The following is a description of a gene set: species: Mus musculus Mouse Gene Set: chr14D2, and this is the list of marker genes: Mlnr-ps, Chmp7, Gm23735, Tnfrsf10b, Nudt18, Gm4251, Gm22725, R3hcc1, 4930434J06Rik, Gm4240, Ccar2, Egr3, Npm2, Xpo7, Nkx2-6, 4930429C20Rik, Dmtn (NCBI Gene Id 13829), 2410012E07Rik, Gm16867, 1700092C10Rik, Gm27179, Bmp1 (bone morphogenetic protein 1), Rps2-ps5, Pdlim2, Phyhip, Loxl2, Entpd4 (ectonucleoside triphosphate diphosphohydrolase 4), Polr3d, Lgi3, Reep4, Gm41206, Gm16677, Mir6950 (NCBI Gene Id 102465573), Gm9192, Sftpc, Gm41192, Bin3, Dok2, Gm27222, Fgf17, Fndc3a, Sorbs3, Gm24890, Gm37762, Gm31748, Nkx3-1, Mir320, Gm9174, Gm9195, Synb, Gm27174, Gfra2, Gm33524, Stc1, Slc39a14, Fhip2b, Gm21451, Pebp4, Gm20236, Slc25a37, Ppp3cc (protein phosphatase 3, catalytic subunit, gamma isoform), Entpd4b, Hr, Gm17740, Gm27177, Gm4606, Piwil2, Rhobtb2, 9930012K11Rik